The following is a description of a gene set: studied in species Homo sapiens Human Gene Set: GSE39820_CTRL_VS_IL1B_IL6_CD4_TCELL_DN Genes down-regulated in comparison of untreated CD4 T cells versus those treated with IL1B and IL6. from publication Lee Y, Awasthi A, Yosef N, Quintana FJ, Xiao S, Peters A, Wu C, Kleinewietfeld M, Kunder S, Hafler DA, Sobel RA, Regev A, Kuchroo VK (PMID 22961052) TGF-beta3 produced by developing Th17 cells induces highly pathogenic T cells that are functionally and molecularly distinct from TGF-beta1-induced Th17 cells. The microarray data represent a distinct molecular signature for pathogenic versus non-pathogenic Th17 cells., and this is the list of marker genes: DENND11, GZMA, MMP7, MALT1, MXI1, GEM, MARCHF7, RIOX2, ZFP91, BLCAP, NDRG4, CASP6, DSP, ZNF597, CRISPLD2, VPS54, DUSP22 (NCBI Gene Id 56940), DGKK (diacylglycerol kinase kappa), GPM6B, HPS3, FNDC3A, ALCAM, PLEK, TM4SF1, KLC4, PDPN, ARMCX3, SERPINF1, ATRNL1, HSPA1A, TIMP1, SH3RF1, FOSL1, RHOQ, ARRDC4, SMOX, CEP19, SLC19A2, BARHL1, SLC25A51, APPL2 (adaptor protein, phosphotyrosine interacting with PH domain and leucine zipper 2), IL22, ETV1, TSPAN5, MAMDC2, NR1D1, MAP3K5, VPS26C, FLOT1, MLANA, ITGA2, GJA1, KLRC2, DNAAF10, MAP2K6, RAB5A, FGF14, ATG12, ZFYVE28, IL33, ZNF622, ARHGAP12, NFE2L2, SMAD3, MTSS1, PPP1R15A, ETV6, KLHL6, HLA-DMB, ZNF471, S100A6, PRDM1, KCTD18, ATP10D, PHF21A, MT1E, PLAC8, AMZ2, ITGA3, ERMN, SLAMF1, LMAN2, KAT2B, MGARP, REEP2, DDX3Y, HSPA5, ALPK2 (alpha kinase 2), TWSG1, DCTN4, ERN1, TAPT1, RAPGEF2 (Rap guanine nucleotide exchange factor 2), MCTP2, HADH, N4BP3, ARIH1, ZFP36, BTBD8, PSMC6, NXPE3, LPXN, MBOAT1 (NCBI Gene Id 154141), PAXBP1, JAK2, UBQLN1, DCDC2C, SMIM3, CCDC71L, BEND4, HSPA1B, C15orf48, ERLIN1, KDM5D, DLG2, ZFP36L2, IL7R, CHM, CYSLTR2, SDCBP2, MAF, BCL2L15, ABCA1, TPBG, CREBZF, SLC30A4, ACAP1, CYYR1, NDEL1 (nudE neurodevelopment protein 1 like 1), SRGN, IL21, NAT14, CYSLTR1 (NCBI Gene Id 10800), TMEM43, NSD3, NKG7 (natural killer cell granule protein 7), ADPRM, PTPRJ, MCFD2, AKR1C3, FYCO1, RANBP9, DACH2, CD109, SEMA4F, CDH17, DENND3, DPY19L3, EBF1, AREL1, SQSTM1, UNC79, ANKRD46, SF3B1, RAB4A, XKR6, MT2A, GRK5, RAPGEF5, IL17A, COX18, DNAJA4, CYP11A1, CD200, STX7 (NCBI Gene Id 8417), EGLN3, POLR2G, CEP55, SLC13A3, SPECC1, MAGEF1, UTY, SKAP2, EGR2, RSRC2, IL1RN, DNAJB9, UPP1, TEX26, PNISR, MFHAS1, FRMD4B, TNFAIP3, NEK6 (NIMA related kinase 6), PAPSS1, MNT, CDKN2AIP, ITGA7, CWF19L2, KLHL24, FGA (fibrinogen alpha chain), LAMC1, ESCO1, WDR91, CHD7, SOCS3, SLC17A9, WDR81, SERPINE1, CHMP5